Given this list of marker genes HS2ST1, BCL6, RNA5SP382, USP34 (ubiquitin specific peptidase 34), UEVLD, CALM3, DNAAF3, ATAD2B, SREK1IP1, FRYL, COL4A2, NET1, EED, DPM1, INTS13, BABAM2, RRAS2, GET3, POLR1A, PIF1, NOL8, SLC38A2, DIPK1A, SCFD1, CLRN3, PRDM1, PDS5A, LSG1, MLH3, LINC02057, CCDC59, SYVN1, SOCS4, TIAL1, PRPF19-DT, REG4, MOCS3, FEZ2, GEN1, ANK3, ARPC4-TTLL3, GRIPAP1, UBE2A, NDUFA4, LRRC57, PAPOLG, FUS, CDC14B, VPS50, SNORA63B, NR6A1, ATPSCKMT, LRPPRC, PRKCI, LAMTOR5-AS1, COQ5, EPB41L2, EVI5, MCCC2, DBNL, C6orf62, SRI, SPATS2L, UQCRC2 (NCBI Gene Id 7385), H3C6, C6orf226, POLG-DT, GOLGA5, SELENOF, ZDHHC5, CDIPTOSP, AKAP3 (NCBI Gene Id 10566), NR3C1, TEP1, EGF, ERAP1, PRRC1, RNY3P15, IFT52, NDUFA9, RNF185, SIRT4, SNX8, SUCO, SNORA81, MAPK10, BZW2, ARL6IP5, MAPK6, EIF3B, MIR194-1 (microRNA 194-1), IL23R, CPSF2, CENPP, FAM53C, TAS2R2, LRIG2, LRRC41, SCAPER, CCT5, COMMD6, HIBCH (NCBI Gene Id 26275), LYSMD3, RFESD, CALM2, USP3, MARCOL, C4orf33, STK31, WASF2, CFL1P1, SNORD45B, PRPF19, UFSP2, PRMT1, PLGRKT, FLVCR1, CCDC192, TADA3, MYL12A, KIAA1143, CD164, SERPINB10, HMGCR, YAE1, PTCD3, DNAJB14, PPP4R1, NDUFB1, ATP8A1-DT, PPARG, E2F7, TAX1BP1, DPY19L4P2, RAD51AP1, FBXO38-DT, SAP30BP, NFXL1, POM121, PSMC2 (proteasome 26S subunit, ATPase 2), ANKMY2, FBXO38, ENSG00000239137, LIN54, SKAP2, CDK17, UQCRH, HEXIM1, PTPRO, MAST4-AS1, FNBP4, LINC01214, SPRED2, CFAP96, NNT, ERC1, NIN, RPL32P3, CWC27, KBTBD2, KLF5, ROCK2, CSPP1, RTN4, TTN-AS1, SRSF2, TES, POLR1G, ACAA1, RPS19, GOPC, DLG1, CSNK2A1, ATP8A1, ULK4, PPP1R8P1, FLCN, MFSD11, SEMA3C, SMC3, PPP1R13L, FERRY3 (NCBI Gene Id 57200), EIF4A2, ENSG00000236098, CDH11, VTA1, CHASERR, TUBA1B-AS1, ARPC4, SP1, DUT, MRPS30, COPS5, LAMTOR5, MAST4, ELF1, SSH2, ANKRD13A, CAPZA2, TAF15, GLIPR1L2, INAVA, MCM3, CCNI, CENPE (centromere protein E), TRAPPC6B, CCDC91, MIR620, EPS8 (EGFR pathway substrate 8, signaling adaptor), CDC42SE2, RPL19, CDIPT, GYS2, TRIM31, POLG, DOHH, RNU5A-1, ATF7IP (NCBI Gene Id 55729), MT-TP, FOXD1-AS1, ZBTB24, ANKRD17, ENSG00000257746, PIK3R3, ARRDC3, NPM1, C21orf91, MGRN1 (mahogunin ring finger 1), PSME2P3, LARP4, ENSG00000238645, DRAIC, here is a description of the gene set: Genes containing one or more binding sites for (EMX1) in their promoter regions (TSS -1000,+100 bp) as identified by GTRD version 20.06 ChIP-seq harmonization. Human Gene Set: EMX1_TARGET_GENES from publication Yevshin I, Sharipov R, Kolmykov S, Kondrakhin Y, Kolpakov F (PMID 30445619) studied in species Homo sapiens